The following is a description of a gene set: Cluster 2: genes changed in primary keratinocytes by UVB irradiation. species: Homo sapiens Human Gene Set: SESTO_RESPONSE_TO_UV_C2 from publication Sesto A, Navarro M, Burslem F, Jorcano JL (PMID 11867738) UV radiation is the most important environmental skin aggressor, causing cancer and other problems. This paper reports the use of oligonucleotide microarray technology to determine changes in gene expression in human keratinocytes after UVB treatment. Examination of the effects of different doses at different times after irradiation gave a global picture of the keratinocyte response to this type of insult. Five hundred thirty-nine regulated transcripts were found and organized into nine different clusters depending on behavior patterns. Classification of these genes into 23 functional categories revealed that several biological processes are globally affected by UVB. In addition to confirming a majority up-regulation of the transcripts related to the UV-specific inflammatory and stress responses, significant increases were seen in the expression of genes involved in basal transcription, splicing, and translation as well as in the proteasome-mediated degradation category. On the other hand, those transcripts belonging to the metabolism and adhesion categories were strongly downregulated. These results demonstrate the complexity of the transcriptional profile of the UVB response, describe several cellular processes previously not known to be affected by UV irradiation, and serve as a basis for the global characterization of UV-regulated genes and pathways., and this is the list of marker genes: ZNF146, USP11, EMP1, TIAL1, HNRNPU, DUSP4, MAP1A, ZKSCAN1, F3, NR3C1, ERBB3, CUL3 (NCBI Gene Id 8452), PCMT1, GCLC, TOP1, PSME4, IFNGR2, RAD21, STXBP3, ZNF185, OAS1, JAG1, KANK1, NRIP1, PSMD14, WIPF2, CCNG1, MORC3, HNRNPK, XPO1, PTPN12, UBE2H, SRPK2, FNTA, ANXA3, SLC6A14, KAT6A, CXADR, CTPS1, RAF1, HIF1A, TJP1, UGCG, ELL2, CTDSP2, GFUS, YY1, ATP13A3, TRIP10, PLSCR1, KIF5B, SRSF4, FAT1, TFAP2A